The following is a description of a gene set: CD25+ regulatory T cells develop in the thymus (nTregs), but may also be generated in the periphery upon stimulation of naive CD4 T cells under appropriate conditions (iTregs). The mechanisms that regulate the generation of peripheral iTregs are largely unknown. We used microarrays to gain insights into the molecular program of extrathymic Treg development. Genes down-regulated in comparison of CD25- T cells treated with IL4 at day 10 versus untreated CD25- T cells at day 10. from publication Prots I, Skapenko A, Lipsky PE, Schulze-Koops H (PMID 21347372) Human Gene Set: GSE24634_IL4_VS_CTRL_TREATED_NAIVE_CD4_TCELL_DAY10_DN studied in species Homo sapiens, and this is the list of marker genes: LAP3, CST6, UBE2L6, ATP6V1E1, METTL1, SLC35B1, GEM, DHX58, TNS3, NETO2, TAP2, MNDA, RHOQ, NLRP3, ST3GAL5, BAK1, TBL2, YARS1, CLIP1, IFT27, TALDO1, DAG1, ASRGL1 (asparaginase and isoaspartyl peptidase 1), DNAJA1, INSR, SNX10, HSPA6, SPR, ACO2, OGFRL1, LONP1, PSMB6, AGA, PYGB, CLDN7, CYBB, PYGL, DUSP5, SOD2, VPS11, LEPROT, CCR1, SLC2A6, CXCL8, HSD11B1, ACSL1 (NCBI Gene Id 91249), PSMA6, DYNLT1, PSMA3, MT1G, ACOT9, IRF7, CKAP4, CASP1, MT2A, KLHL18, TRPV2, KIAA0513, RMDN3, GLRX2, APOBR, FADS1, FCGR2C, GRN, TSEN34, ERLIN1, UPP1, SORT1, DHRS9, ABR, LYN, GPC4, LRP12, ZNF185, RABEPK, CEBPB, CDKN1A, CAVIN1, RAB5IF, CTBP2, ATP6V0A2, RCN1, PSME2, SQOR, MYOF, CPD, APOO, TLR1, NRP1, BLVRB, RRAD, IRF1, CD86, GK, INHBA, CTNNA1, PHGDH, TNFAIP6, RTN1, SCG5, MSRB1, CRYBG1, TXN, ADAMDEC1, HK3, GREM1, SYNGR1, PIR, TLR8, CARS1, RAB20, SLC27A3 (solute carrier family 27 member 3), HMG20B (high mobility group 20B), F3, RAB31, SLC31A1, DNM1L, SFT2D2, APP, CTSO, MYD88, AK2, NR1H3, PLA2G4A, IMPA2, IGFBP6, CDS2, GBP2, CALCOCO2, IQGAP2, PLAUR, DNPEP, SH3GLB1, FZD1, UQCRC1, MT1H (metallothionein 1H), ANXA4, MICALL2, SCRN1, ECHDC3, CFB, KYNU, MT1X, COL8A2, TXNRD1, PGD, ABHD5, TBC1D9, ATP1B3, STYXL1, ALAS1, ATP6V0B, STX11, STT3A, TPBG, BCL2L2, HLA-DPA1, CDA, ATG3, SECTM1, SPG21, ERI2, USP25, PTAFR, GK3, CGGBP1, ATP6V1B2, RIN2, DSE (NCBI Gene Id 29940), GBP1, C3, SLC30A1, P4HA2, TCIRG1, LMO4, CREG1, TYROBP, CIAO2B, CDCP1, PSMD5, IFIT3, STAT1, PDE4DIP (NCBI Gene Id 9659), STX3, STAP2, WARS1, YIPF1, SERPING1, GLRX3, TUBB6, FZD2 (frizzled class receptor 2), DHRS3, PLXND1, RAI14, IGF2R, ATP6V0C, CLIC4, IL1RN, S100A13